Given this list of marker genes BNC2, PPP3CA, CRIM1, TNRC6B, RASGRP1, GATAD2B, LEMD3, EPHA4 (NCBI Gene Id 401031), SCML2, UBE4A, EHD1, AP1AR (adaptor related protein complex 1 associated regulatory protein), ZNF704, NAA50, MBNL1, KRIT1, DNAJC16, PPP1R3A, PELI1, JAG1, RHOB, RPS6KA3, ASPN, SMAD7, ZNF367, PDCD4, PSRC1, CPEB3, TIMP3, PITX2, STAG2, PLAG1, NF2, PPARA, SOX5, HNRNPK, PBRM1, NTF3, UBE2D3, MATN2, PCDH17, TRAPPC8, GID4, SRSF3, TAGAP, TGFBI, FUBP1, CREBRF, STK40, RNFT1, KLHL42, FCHO2, UBR3, YOD1, CDC25A, ACBD5, ING3, TRPM7, FBXO11, ARID1A, RNF111, THRB, PAN3, PLEKHA1, PIK3R1, CNTFR, CCER1, ZNF654, PER2, SKI, PCBP1, YAP1, MTAP, RNF103 (NCBI Gene Id 7844), MRPL9, DAZL, PURB, CASKIN1, BTBD3, SATB1, ELF2, XKR6, RAB11A, OSR1, SPRY2, SOX6, AGO2, ARGLU1, CCL1, PCBP2, BAHD1, GLCCI1, BRD1, WWP1, SFSWAP, MPRIP, ZCCHC3, ARHGAP24, SOX2, PCSK6, CHD7, TGFBR2, PHF14, FASLG, RECK, ALX1, STAT3, CREBL2, MIR137HG, JPH1, BOLL, ADGRG2, CBX4, RMND5A, SPRY1, KCNA3, NFIB, ITPRID2, here is a description of the gene set: species: Homo sapiens Human Gene Set: ATAAGCT_MIR21 Genes having at least one occurence of the motif ATAAGCT in their 3' untranslated region. The motif represents putative target (that is, seed match) of human mature miRNA hsa-miR-21 (v7.1 miRBase).